The following is a description of a gene set: Abnormal liver morphology Human Gene Set: HP_ABNORMAL_LIVER_MORPHOLOGY Any structural anomaly of the bile-secreting organ that is important for detoxification, for fat, carbohydrate, and protein metabolism, and for glycogen storage. species: Homo sapiens, and this is the list of marker genes: COX4I2, GLIS3 (GLIS family zinc finger 3), RMRP, NDUFS8, POLG2, CYBC1, TFR2, PC, CEP19, ENPP1, CC2D2A, PEX5, EFL1, APOE, SCN4A, MCM4, IL12RB1, UROD, TRAPPC11, BLNK, DOCK6, FBN1, PCYT1A, IFT56, SRSF2, LMBRD1, PEX1, TRMU, PKHD1, FERMT3, DPAGT1, BRCA2, SLC38A3, SOX10, CLCA4, NDUFAF3, DYNC2H1, ATP8B1, RRAS2, FDX2, SLC25A19, COA8, DPM1, PGM1, NGLY1, SKI, CBL, HGSNAT, AGA, XRCC4 (X-ray repair cross complementing 4), PDGFB, ICOS, ALDOA, DZIP1L, MLXIPL, SURF1, KDM1A, RABL3, BBS9, FGA, SFTPC, PEX14, BBS4, DKC1, RPGRIP1L, IL2RB, ARL6, KIF3B, CPOX, GBE1, GDF2, NAGLU, PARN (poly(A)-specific ribonuclease), FOXP3, IL17RC, SERPINA1, TMEM199, FARSB, HBG1, DYNC2I1 (NCBI Gene Id 55112), ERCC8, TFE3, PDPN, HJV, COG5, ALG9, STAT1, ATP6AP2, PKD2, JAG1, MMAB, ACVR2B (activin A receptor type 2B), BMPER, BBS12, TERT, BMP2, C2orf69, ESAM, TUFM (Tu translation elongation factor, mitochondrial), NPHP4, NDUFB11, SGSH, WDR35, OCLN, GANAB, ACBD6, MFN2, PLEKHM1, GALM, ADRA2A, EXTL3, STX11, SC5D, SUMF1, FOXN1, PNPLA2, FTL, SOS1, CYP19A1 (cytochrome P450 family 19 subfamily A member 1), PDGFRL, IKBKG, BSCL2, LMNB2, ETFB, PHEX, CHD7, ALG1, KCNN4, SFTPA2, KRIT1 (NCBI Gene Id 9602), XIAP, TP53, TREX1, LZTFL1, GPR35, LCAT, HBG2, RFT1, HSPG2, MMACHC, HYMAI, SBDS, PIK3CG, COG8, MPL, CD28, PEX6, HMOX1, SH2D1A, PSMB4, NFS1 (NCBI Gene Id 96810), MPC1, ARPC5, RMND1 (required for meiotic nuclear division 1 homolog), PRKCZ, LUZP1, JAK3, MT-TK, ZFYVE19, CD70, KIT, MMEL1, CASR, JAK1, GALNS (galactosamine (N-acetyl)-6-sulfatase), MMP23B, ATP6AP1, USP53, COG1, APOB, SLCO1B3, KIF20A, PCCA, SLC25A13, RIT1, SPTB, GALT, HNF1A, EDNRA, TMEM67, IDS, ABCB4, ABCC8 (ATP binding cassette subfamily C member 8), ARSB, PTEN, PEX3, CLPB, PRDX1, RAG1, IFT80, CPT2 (carnitine palmitoyltransferase 2), B2M, ACADS (acyl-CoA dehydrogenase short chain), TYMS, SLC30A10 (solute carrier family 30 member 10), ABCC6, KMT2B, RHCE, IARS1, MT-ND1, VPS33B, POLG, ACVRL1, RFXAP, KCNQ1OT1, PRKCD, SAMHD1, JAM3, NPHP1, SLC11A1, NDUFS4, HNF4A (NCBI Gene Id 4339), CSPP1, NDUFA1, LRPPRC, RNASEH2C (ribonuclease H2 subunit C), PYGL, ATP7A, TGFB1, ACOX1, RHD, SLC51B, NDUFB3, NSMCE2, SLCO2A1, TNFRSF13B, FASLG, HNRNPA2B1, MAPK8IP3, VPS4A, FLT1, NEK1, CD96, TLR8, SLC17A5, COG6, PEX10, TSFM, CTNS, DNAJC19, BRCA1, SNX14 (sorting nexin 14), TCF3, HBA2, SLC39A7, IFT43, KRAS, G6PC1, ABCD3, VPS11, CDKN1C, ALG2, NDUFS3, ATP5MK, STOX1, ANTXR1, MECOM, SNX10, LYST, IL6, TRMT5, CASP8, NCF2, NOP10, RBCK1, MVK, TMEM165, BAAT, USP18, SLC26A9, ALDOB, IL21R, APC, BBIP1, SPTA1, TRAF3IP1, ATP7B, SLC2A1, PHKG2, ATPAF2, APOC2, RAF1, CTNNB1, PIGA, DYNC2LI1 (dynein cytoplasmic 2 light intermediate chain 1), FAS, GCLC, GATA2, FOXRED1, GUSB, TOMM7, UNC13D, KCNJ11, MYBPC3, PLAGL1, SLC9A3, SUCLG1, LBR, NDUFS6, BAP1, SLC11A2, LSM11, FUCA1, PTPRC, SLC4A1, SASH3, SF3B1, PALB2, RBPJ, LYZ, SCARB2, ABCG8, BBS2, CDKN2A, MEFV, XYLT1, MT-ND3, NDUFS2, FTH1, HEPACAM, HNRNPA1, TNFSF15, NDUFA2, SLC2A2, NDUFB9, ARMC5, IRF4, STXBP2, KRT18, ERCC4, IFNG (NCBI Gene Id 3458), BTD, MTTP, TCN2, ELN, INPP5E, TNNT2, KPTN, GNPTAB, SEMA7A, IGHG2, NPC2, PSMB9, CYP7A1, ABCA1, MRPL3, PSMB10, IRF1, BTNL2, NPHP3, SPI1, POU2AF1, SYK, CYP27B1, MICU1, DDOST, CYP7B1, SDCCAG8, AUH, PEX16, CASZ1 (castor zinc finger 1), GPC4, MYL2, SKIC2, BLM, SLC7A7, IL1RN, GUCY2D, TCTN1, CARS2, ASL, FARSA, NFKBIA, VPS13A, DLD, AIRE, IGLL1, RASGRP1, SLCO1B1, PRDM16, DOCK2, PSTPIP1, STX1A, NAE1, ASAH1 (N-acylsphingosine amidohydrolase 1), HSD17B4 (NCBI Gene Id 3295), ABCC2, IL7R, MYRF, TXNDC15, CIDEC, PDGFRA, PUS7, SPRED2, AP1S1, HAMP, SPIN4, RORC, IQCB1 (NCBI Gene Id 9657), PPARG, SCYL1, GABRD, STAT3, RTL1, CD3E, COX14, UROS, KCNN3, CTLA4, CPT1A, ABCA12 (ATP binding cassette subfamily A member 12), RAG2, PIK3C2A, GCDH, EWSR1, NDUFAF2, BMP6, HEXB, NAA10, NCKAP1L, ZAP70, KCNQ1, CD19, TRIM37, ZNFX1, LPL, POLR3A, IL17RA, RHBDF2 (rhomboid 5 homolog 2), GBA1, COX15, WDPCP, CFTR, MED12, HBB, RNU4ATAC, ACADVL, MARS1, TNFRSF1A, CORIN, C1S, CTSA, GSTM3, FADD, MUC5B, CLCN7, DYNC2I2, RHAG, POT1, SMAD4, PEX2, MIF, BICC1, NUBPL, RTEL1, NCF4, SLC6A14, ARG1, ATRX, MTX2, DOCK11, JAM2, TMEM237, MAP2K1, MT-ATP8, NEU1, AP3B1, DCDC2 (doublecortin domain containing 2), ETFDH, TET2 (tet methylcytosine dioxygenase 2), LRP5, NDUFS7, TSC2, IGF2R, CAV1, ZNF699, SDHD, REL, COG4, MPV17, PIEZO1, MRPS28, AXIN1, KCNH1 (potassium voltage-gated channel subfamily H member 1), VPS45, FAH, MT-ND5, ATP6V1B2, CCDC47, SLC51A, ATP5F1E, CD247, RPGRIP1, NDUFAF5, NCF1, PCK1, ACAD9, TNPO3, ENG, LIG4, SHPK, PEX26, PDCD1, ASS1, MYORG, TMEM216, IFT172, ANKRD55 (NCBI Gene Id 79722), CYBB, PEX12, YARS2, CTSK, ANK1, LPIN2, DNASE2, TMEM70, ADAMTSL2, GNS, PTRH2, IFT74, KLF1, ABCG5 (ATP binding cassette subfamily G member 5), VCP, TYMP, USB1, ERCC1, SCO2, CD55, WT1, ASXL1, LIPE, RAC2, RNU7-1, HCK, HMGCL, CA2 (carbonic anhydrase 2), NDUFV1 (NCBI Gene Id 4723), EARS2, AGR2, AGGF1, DIS3L2, BBS5, NAGA, MET, SPTBN1, SH2B3, SKIC3, TMEM107, HSD3B7, MT-ND4, SCO1, TTC21B, CP, KCNAB2, RRAS, MT-TN, SCAPER, MMUT, SLC35C1, KIF12, PEX19, MYO5B, BBS1, TFAM, SPEN, RNASEH2A, HPGD, FBP1, ACTG2, ALDH1A2, TOGARAM1, ANKS6, SAR1B, PEX13, SLC29A3, INSR, VIPAS39, AHDC1, COX5A (cytochrome c oxidase subunit 5A), CD79A, TRIM32, PMM2, AMACR, LRRC8A, ACP5, LAMA5, HFE, TNNI3, IL18BP, LDLRAP1, IGF2, GALK1, B9D2, MT-CYB, JAK2, NOTCH1, AKT2 (NCBI Gene Id 208), BOLA3, MCTS1, MEG3, CAVIN1, CD3D, ADAR, GNE, DNASE1L3, F5 (NCBI Gene Id 98271), GPC3, TKFC, TALDO1, HMGCS2, SLC39A4, PRF1, PIGM, TNFRSF13C, DLL4, MYD88, NHP2, UBR1, AHCY, RBM8A, DVL1, MOGS, NDUFS1, GALE, GNAS, RASA2, BBS10, LDLR, IRF8, ERCC6, TRAC, UQCRB, MT-TE, IRAK4, IFT122 (NCBI Gene Id 55764), LACC1, TRPV6, PPP1R21, CD79B, DCTN4, ALG5, CYP2R1, RECQL4, PTPN2, AGL, IGHM, XPR1, MT-TW, CTSC, NDUFAF8, SRP54, PRKCSH, FCGR2A, UCP2, CEP164, HMBS, STX5, DHCR7, ZIC3, EPB42, ARHGAP31, PKD1, HADHA, RERE, CEACAM6, CALR, OTUD5, SLC20A2, ALG13, CEACAM3, TNFRSF1B, TBX1, IL2RA, NPC1, TRAF3IP2, ACADM, SMPD1, RIPK1, DNAJC21, IRF5, B9D1, PIK3CA, RFX5, MAGT1, COG7, ABHD5, MMAA, C4B, SLC37A4 (NCBI Gene Id 84965), MKKS, EIF2AK3, BTK (NCBI Gene Id 695), SPIB, CD40LG, LZTR1, PNPLA6, NAF1, CIITA, TTC8, MCCC1, CNTNAP2, SLC25A15, DHDDS, CASP10, NHLRC2, ERBB3, PI4KA, DPM2, OFD1, OSTM1, RFXANK, CD27 (CD27 molecule), DGUOK, GLRX5, SERPINC1, IDUA, DNAJB11, PIGS, IL6ST, PALLD, IL17F, ADK, BRAF, PSMG2, STAT4, ATP5F1D, IFT27, FARS2, ITCH, LYN, INPPL1, CCDC115, PSMB8, SLC19A1, DHFR, TCIRG1, FAM111B, TKT, MYPN, GNMT, PTPN22, PIK3CD, HLA-DRB1, NDUFB10, UBE4B, CD81, GNB2, PCCB, ARL13B, FOCAD, CLDN1, GPD1, FGFR2, G6PC3, HYOU1, TMEM126B, PRIM1, SOS2, AP1B1, AKR1D1, IFIH1, SLC25A1, NR1H4, ADA2, ACSL5, ITK, NEK8, NDUFAF4, MT-TL1, IFT140, CFAP418, MST1, TJP2, LIPA, BBS7, ETFA, INVS, MAN2B1, DDRGK1, MRPS7, WRAP53, CDAN1, MADD, SEC63, ACAT1, CR2, TBX19, TIMMDC1, ALG8, WDR19, MRAS, DLK1 (delta like non-canonical Notch ligand 1), PDGFRB, PIGL, RINT1, NLRP1, ALMS1 (ALMS1 centrosome and basal body associated protein), NRAS, POLD3, TNFSF11, GAA, CDIN1, SLC22A5, IL2RG, NSD2, SLC34A2, PIK3R1 (NCBI Gene Id 5295), POLD1, TARS2, TERC, ATAD3A, PCSK9, GIMAP5, PCK2, HBA1, BCS1L, VPS33A, PEPD, PKLR, TULP3, GPIHBP1, MT-ATP6, SCLT1, FLNC, IL12A, XK, STIM1, MPI, MT-ND6, LARS1, RNASEH2B, NAGS, ADA, PHKA2, NOTCH2, FBXL4, TPP2, EOGT, MT-ND2, ABCB11, TCTN3, YARS1, HADH, STEAP3, RAB27A, TTC7A, PLAAT3, CCDC28B, LMNA, MT-TV, AP3D1, NDUFA6, LIG3, C1QBP, DCLRE1C, NDUFAF1, IFNGR1, CEP290, CLEC7A, NPM1, PLIN1, MKS1, MICOS13, PSAP, SDHA, LTBP3, NLRP3, SP110, AGPAT2, LYRM4, HNF1B, NEUROG3, NDUFV2, PTPN11, GLB1, TINF2, SEMA4D, TCF4, B4GALT1, FECH (ferrochelatase), MRPL44, HADHB, TSC1, CTC1, STN1, IGKC, RUNX1 (RUNX family transcription factor 1), TMEM231, TNFRSF11A, APOA1, RRM2B, DEF6, GFM1, SHARPIN, FOS, UNC45A, NDUFA11, HAVCR2, PHKB, CYBA, SOCS1, ZPR1, SAA1, SLC25A20, TCTN2, PEX11B, CBS, ATP5F1A (ATP synthase F1 subunit alpha), SLC40A1 (solute carrier family 40 member 1)